The following is a description of a gene set: Signaling by NOTCH1 Human Gene Set: REACTOME_SIGNALING_BY_NOTCH1 species: Homo sapiens, and this is the list of marker genes: NOTCH1, ADAM10 (ADAM metallopeptidase domain 10), JAG1, CREBBP, HDAC9, APH1A, HES5, MAMLD1 (NCBI Gene Id 653998), TLE3, ARRB1, PSENEN, HDAC1, SKP1 (S-phase kinase associated protein 1), HDAC7, KAT2B, DNER, NUMB, NEURL1B, FBXW7 (F-box and WD repeat domain containing 7), RBX1, MIB2, ITCH, ADAM17, UBC, MAML3, HES1, HEY1, MAML2, KAT2A, TBL1X, HEY2, APH1B, HDAC10, HDAC5, PSEN1, UBA52, HDAC2, NCOR2, HDAC8, TLE2, UBB, RBPJ, DLK1, NCOR1, NEURL1, HDAC3, MAML1 (mastermind like transcriptional coactivator 1), EP300, HDAC11, MYC (NCBI Gene Id 731404), TLE4, DLL1, CNTN1, ARRB2, DLL4, NCSTN, HEYL (NCBI Gene Id 92408), CDK8, MIB1, HDAC4, CCNC, SNW1, DTX4, NBEA, TBL1XR1, HDAC6, CUL1, JAG2, RPS27A (NCBI Gene Id 6233), PSEN2, TLE1, DTX1, HIF1A, DTX2